The following is a description of a gene set: RNA polymerase I, one of three nuclear DNA-directed RNA polymerases found in all eukaryotes, is a multisubunit complex; typically it produces rRNAs. Two large subunits comprise the most conserved portion including the catalytic site and share similarity with other eukaryotic and bacterial multisubunit RNA polymerases. The remainder of the complex is composed of smaller subunits (generally ten or more), some of which are also found in RNA polymerase III and others of which are also found in RNA polymerases II and III. Although the core is competent to mediate ribonucleic acid synthesis, it requires additional factors to select the appropriate template. Mouse Gene Set: GOCC_RNA_POLYMERASE_I_COMPLEX studied in species Mus musculus, and this is the list of marker genes: Polr2k (NCBI Gene Id 17749), Polr2f, Polr1f, Polr1a, Polr2h, Polr1d, Polr1h, Polr2e, Polr1c, Polr2l, Polr1g, Polr1e, Polr1b